Given this list of marker genes EIF2B2, RNPC3, LAD1, TOR2A, RTP4, ACY3, CD83, ENDOU, FOXI1, SAPCD1, CR2, NRL, IL6, PFDN5, RMDN3, CCR10, SERPINF2, SRSF7, ATP13A2, NEURL1, HYI, RWDD4, FLYWCH2, UQCRC2, DIMT1, PSMD4 (NCBI Gene Id 5710), SLC17A2, PCDH15, GADD45B, PRPF40A, PHOX2A, CLU, EPHA4, RRP7A, HILPDA, COL22A1, NAPB, LDLRAD4, EBP, CACNG1, ZFAND5, RPS6KB1, MTMR10, FBN2, PPP1CB, PHAX, USP29, DUOXA2, TELO2, LIAS (NCBI Gene Id 94182), GPR37L1, SELE (selectin E), PIWIL1, NIF3L1, TNFSF8, FGD1, EIF3K, RHOB, SIL1, ABHD8, CDHR1, LCE3B, ADK, COPS6, NSG2, YBX2, CFD, IFNB1, PDE10A, COMT, GIPC3, SNTA1, DLL4, CCR8, KLHDC3 (NCBI Gene Id 116138), PBX1, STIMATE, MPST (NCBI Gene Id 4357), CELA2A, PRG3, MRC2, EMC8, PLCZ1, SYCP3, GPR162, SLC41A3, STAT4, CDR2L, CHRD, DSP, TNC (tenascin C), PFDN1, NUDT9, ARMC6, PODXL, DDRGK1 (NCBI Gene Id 65992), IRS2, CKMT1B, DACT1, TENT2, ACOT7, LMAN1L, WFDC5 (NCBI Gene Id 23571), DUSP2, SERPINB2, RAD9A, AKR1B1, EGR2, LYNX1, FBP2, SLC27A3, ECE1, TNF, ADAMTSL5, CAP1, CDV3, ZFP42, GPC1, TIMP1, GLDC, THBS2, CCNG2, SEMA6C, GNGT1, STK4, NR4A1, TMEM100, SCUBE1, GJB2, CWH43, JUN, DUSP8, PAK3, STRC, FBXO43, STMP1, SLFN12L, VCAN, ACTL7B, SUCO, NDUFS6, CLEC14A, EBI3, INHBA, PIBF1, KRT85, CXCL2, SGCG, GALK2, CITED2, ASH2L, BEST2, ARID5B, ATF3, IER2, JARID2, ADD2, ZFP30 (ZFP30 zinc finger protein), SMR3A, SIRT1, MRPL22, ONECUT1, SPAG7, OSTF1, CSF1, ZNF274, SOX13, HOXC6, CELF4, SFR1, TMEM176B, C1orf54, CWC15, CKS2, ITPR2, SHMT1, PTGDR, CCL13, GATA5, C2CD2, SLC12A9, F3, CLDN1, MINDY1, HERPUD2 (NCBI Gene Id 64224, HERPUD family member 2), BIK, CHRDL2, VPS45 (NCBI Gene Id 11312), ANKRA2, RGS2, HCRT, PHLDA1, NHERF4, NFKBIZ, TSPO2, PITPNM2, TNP1, ARHGDIG (Rho GDP dissociation inhibitor gamma), HDHD3, HAUS3, here is a description of the gene set: from publication Amit I, Garber M, Chevrier N, Leite AP, Donner Y, Eisenhaure T, Guttman M, Grenier JK, Li W, Zuk O, Schubert LA, Birditt B, Shay T, Goren A, Zhang X, Smith Z, Deering R, McDonald RC, Cabili M, Bernstein BE, Rinn JL, Meissner A, Root DE, Hacohen N, Regev A (PMID 19729616) Genes up-regulated in comparison of dendritic cells (DC) stimulated with LPS (TLR4 agonist) at 1 h versus DC cells stimulated with Gardiquimod (TLR7 agonist) at 1 h. mouse primary BMDCs were stimulated with tlr ligands and gene expression changes were profiled on Affymetrix arrays species: Homo sapiens Human Gene Set: GSE17721_LPS_VS_GARDIQUIMOD_1H_BMDC_UP